Given this list of marker genes Nrp1, Nrp2, Slit3, Smo (NCBI Gene Id 319757), Dscam, Wnt3, Megf8, Wnt3a, Sema5a, Bmpr2, Plxna4, Ryk, Hdac6, Alcam, Plxna3, Wnt5a, Slit2 (slit guidance ligand 2, NCBI Gene Id 338531), Sema3a, Slit1, Cxcl12, Vegfa, Sema3f, here is a description of the gene set: Mouse Gene Set: GOBP_NEURON_PROJECTION_EXTENSION_INVOLVED_IN_NEURON_PROJECTION_GUIDANCE Any neuron projection extension that is involved in neuron projection guidance. species: Mus musculus